The following is a description of a gene set: Mouse Gene Set: GOMF_CHLORDECONE_REDUCTASE_ACTIVITY Catalysis of the reaction: chlordecone alcohol + NADP+ = chlordecone + H+ + NADPH. species: Mus musculus, and this is the list of marker genes: Akr1c6 (NCBI Gene Id 83702), Akr1c20 (NCBI Gene Id 116852), Akr1c19, Akr1c21 (NCBI Gene Id 77337), Akr1c12, Akr1c14, Akr1c13